Given this list of marker genes Ccl19-ps5, Ppbp, C3ar1, Ccl21e, Sell, Ccl19, Ccl21f, Edn1 (NCBI Gene Id 13614), Ripor2, Ccl19-ps3, Dapk2, Ccl21d, Rac2, Tirap, Mospd2, Cd74, Il4 (interleukin 4, NCBI Gene Id 16189), Ccr7, Lbp, Perp (NCBI Gene Id 80493), Camk1d, Dysf, Mcu, C1qbp, S100a14, Ednra, Ccl21b, Ccl19-ps4, Nckap1l, Rac1, Mdk, Il1b, Ccl19-ps1, Ccl19-ps6 (C-C motif chemokine ligand 19, pseudogene 6), Thbs4, Ccl21a (C-C motif chemokine ligand 21 (serine)), Xcl1, C5ar1, Cxcr2, Dnm1l, Il23a, here is a description of the gene set: Mouse Gene Set: GOBP_POSITIVE_REGULATION_OF_GRANULOCYTE_CHEMOTAXIS Any process that increases the rate, frequency or extent of granulocyte chemotaxis. Granulocyte chemotaxis is the movement of a granulocyte in response to an external stimulus. studied in species Mus musculus